Given this list of marker genes APRT, here is a description of the gene set: Normally in humans, adenine formed in processes such as polyamine biosynthesis can be salvaged by conversion to AMP, catalyzed by APRT (adenine phosphoribosyltransferase). In the absence of APRT activity, however, accumulated adenine is instead converted to 2,8-dioxo-adenine. Accumulation of insoluble crystals of 2,8-dioxo-adenine in the kidneys causes the kidney damage that is a major symptom of APRT deficiency in humans (Van Acker et al. 1977; Bollée et al. 2012). Reactome Pathway: Defective APRT disrupts adenine salvage part of: Nucleotide salvage defects species: Homo sapiens